Given this list of marker genes E2f3, Trem2, E2f1, Per2, Ceacam2, Tfdp1, Il4 (NCBI Gene Id 16189), here is a description of the gene set: Mouse Gene Set: GOBP_NEGATIVE_REGULATION_OF_FAT_CELL_PROLIFERATION studied in species Mus musculus Any process that stops or decreases the rate or extent of fat cell proliferation.